Given this list of marker genes CAP1 (NCBI Gene Id 10487, cyclase associated actin cytoskeleton regulatory protein 1), HAT1, CLCN3 (NCBI Gene Id 133073), RNASE4, SEPTIN2, CCZ1, KIF2A, ABCC4, RAB11A, API5, CAPRIN1, CCNH, TM9SF3, PRPS2, CSE1L, CCT8, IFITM1, CNOT8, ITGAV, SFPQ, here is a description of the gene set: Genes down-regulated both in vivo and in vitro upon activation of MET signaling. species: Homo sapiens from publication Seiden-Long IM, Brown KR, Shih W, Wigle DA, Radulovich N, Jurisica I, Tsao MS (PMID 16158056) Human Gene Set: SEIDEN_MET_SIGNALING Both Ki-ras mutation and hepatocyte growth factor (HGF) receptor Met overexpression occur at high frequency in colon cancer. This study investigates the transcriptional changes induced by Ki-ras oncogene and HGF/Met signaling activation in colon cancer cell lines in vitro and in vivo. The model system used in these studies included the DLD-1 colon cancer cell line with a mutated Ki-ras allele, and the DKO-4 cell line generated from DLD-1, with its mutant Ki-ras allele inactivated by targeted disruption. These cell lines were transduced with cDNAs of full-length Met receptor. Microarray transcriptional profiling was conducted on cell lines stimulated with HGF, as well as on tumor xenograft tissues. Overlapping genes between in vitro and in vivo microarray data sets were selected as a subset of HGF/Met and Ki-ras oncogene-regulated targets. Using the Online Predicted Human Interaction Database, novel HGF/Met and Ki-ras regulated proteins with putative functional linkage were identified. Novel proteins identified included histone acetyltransferase 1, phosphoribosyl pyrophosphate synthetase 2, chaperonin containing TCP1, subunit 8, CSE1 chromosome segregation 1-like (yeast)/cellular apoptosis susceptibility (mammals), CCR4-NOT transcription complex, subunit 8, and cyclin H. Transcript levels for these Met-signaling targets were correlated with Met expression levels, and were significantly elevated in both primary and metastatic human colorectal cancer samples compared to normal colorectal mucosa. These genes represent novel Met and/or Ki-ras transcriptionally coregulated genes with a high degree of validation in human colorectal cancers.